Given this list of marker genes NR1D1 (NCBI Gene Id 9572), NKX6-2, PITX3, IDH2, NOTCH1, MYCN, CTNNB1, TP53, MIR146A (NCBI Gene Id 406938), DAB1, LIN28A, HMGA2 (NCBI Gene Id 8091), ID2, DLX2, HES1, NKX6-1, NR2E1, NOG, DLX1, MIR181B1, ASCL2, ABCC8, DRD3, SKI (NCBI Gene Id 6497), TREM2, NTRK3, SOX10, MIR181C, DICER1, SIRT2, RB1, TMEM98, DUSP10, CERS2, LDLR, NF2, RNF10, ATOH1, SOX11, ID4, NF1, GPR37L1, F2, TSPO, DAAM2, HES5, here is a description of the gene set: Any process that stops, prevents, or reduces the frequency, rate or extent of gliogenesis, the formation of mature glia. Human Gene Set: GOBP_NEGATIVE_REGULATION_OF_GLIOGENESIS studied in species Homo sapiens